Given this list of marker genes Pfn1, Cep20, Erh, Tubb4b, Gzmb, here is a description of the gene set: Genes positively differentially expressed in cell type: NK cell upon treatment with cytokine: FasL in mouse lymph nodes in vivo. from publication Cui A, Huang T, Li S, Ma A, Pérez JL, Sander C, Keskin DB, Wu CJ, Fraenkel E, Hacohen N (PMID 38057668) studied in species Mus musculus Cytokines mediate cell-cell communication in the immune system and represent important therapeutic targets. A myriad of studies have highlighted their central role in immune function, yet we lack a global view of the cellular responses of each immune cell type to each cytokine. To address this gap, the authors created the Immune Dictionary, a compendium of single-cell transcriptomic profiles of more than 17 immune cell types in response to each of 86 cytokines (>1,400 cytokine-cell type combinations) in mouse lymph nodes in vivo. A cytokine-centric view of the dictionary revealed that most cytokines induce highly cell-type-specific responses. For example, the inflammatory cytokine interleukin-1β induces distinct gene programmes in almost every cell type. A cell-type-centric view of the dictionary identified more than 66 cytokine-driven cellular polarization states across immune cell types, including previously uncharacterized states such as an interleukin-18-induced polyfunctional natural killer cell state. Mouse Gene Set: CUI_NK_CELL_FASL_RESPONSE_UP